Given this list of marker genes RPS17, RIPOR2, RPL23, SPSB3, CRIP1, ZEB1, TRA2A (NCBI Gene Id 29896), CNNM3, RPL7A, BCL11B, PFDN5, TSC22D3, DGKD, ZNF292, RPL28, MAPRE2, PLAAT4, CD3G, RPL19, TSPYL4, CD247, RPL34, EIF3F, ACD, SP110, ADNP2, GALT, BTG1, VILL, STAT5B, LIME1, STK38, LINC00623, RPS3, NLRP1, TRAF3IP3, EIF4B, ING1, RASA2, BIN2, RPLP2, DOCK9, ZNF91, RPL38, RPS25, OFD1, SH3YL1, SGF29, N4BP2L2, ASXL1, CD6, INTS15, PRKD2, THAP11, HLA-J (major histocompatibility complex, class I, J (pseudogene)), SATB1, MZT2A, HNRNPA1, ACTR5, DPP4, EEF1B2, NACA, FBXO21, TRBC1, CCR7, RPL30, BIN1, PHF1, CLEC2D, RPL35A, PIK3IP1 (NCBI Gene Id 113791), GPR18, PRKCQ (protein kinase C theta), PPP3CC, SP100 (NCBI Gene Id 6672), ALDOC, TCF7, SLC25A38, SNRK, ALDH18A1, RPL14, SIDT1, RPS7, FCMR, PDCD4, EEF1G, HIVEP2, RPS18, RPS23 (NCBI Gene Id 6228), RPS15A, NCK2, PTPRCAP, DIDO1, TRAC, RPL13A, RPF1 (NCBI Gene Id 80135), RPL35 (ribosomal protein L35), HLA-F, RNPS1, MZT2B, IFITM1, EEF1D, URI1, PCSK7, RPS14, SKAP1, CYFIP2, GYPC, RBL2, RPL11, ENO2, ZHX2, PBXIP1, SELL, RPL29, RPL22, ADD3, KMT2A, ARHGAP15, RPS15, SEMA4D, RPL6, ANKRD49, CD3D, TES (NCBI Gene Id 26136), RCN2, NRF1, RPS10, PLCL2, SAFB2, ABLIM1, CD3E (CD3 epsilon subunit of T-cell receptor complex), RASGRP1, INPP4A, LRBA, VPS51, KLF2, ITPR3, RASA3, IL32, RPL10L, ITGA4, RPL17, RPS10P5, SMCHD1, RPS29, NSUN5, ZNF430, PLSCR3, RPL26, COX11 (NCBI Gene Id 1354), UXT, BICRAL, RHOH, ECHDC2, GATA3, CD96, TMEM131L, EIF3K, RNF126, WDR59, PRKCH, NELL2, IPCEF1, UBA52, ISG20, PILRB (paired immunoglobin like type 2 receptor beta), GPSM3, CD37, CDC25B, FAU, RPL36, PARP16, KBTBD4, RPL3, RPS27, FOXJ3, NOP53, RETREG1, RPL31, BTN3A1, ZNF44, JADE2, ITGB7, ICAM2 (NCBI Gene Id 3384), ELK3, CDC7, BCL2, GCFC2, RPL21, RPL5, ACAP1, LEF1, LSM14A, CBX7, MYCBP2, SLC16A7, DGKA, MYLIP, here is a description of the gene set: Immune cell-specific expression is one indication of the importance of a gene's role in the immune response. In order to identify such patterns, we set out to broadly profile gene expression in a variety of immune cells. Human Gene Set: GSE22886_NAIVE_TCELL_VS_DC_UP from publication Abbas AR, Baldwin D, Ma Y, Ouyang W, Gurney A, Martin F, Fong S, van Lookeren Campagne M, Godowski P, Williams PM, Chan AC, Clark HF (PMID 15789058) species: Homo sapiens Genes up-regulated in comparison of naive CD4 CD8 T cells versus unstimulated dendritic cells (DC).